Given this list of marker genes Prdx1, Aacs, Calr, Fchsd2, Nsmce3, Idi1, Fabp5, Aldh9a1, Hmgcs1, Pfn1, Gng12, Ly6d, Eef2kmt, Ak2, Ctnnbl1, Hfe, Cfl1, Sdf2l1, Cpped1, Nme1, here is a description of the gene set: Cytokines mediate cell-cell communication in the immune system and represent important therapeutic targets. A myriad of studies have highlighted their central role in immune function, yet we lack a global view of the cellular responses of each immune cell type to each cytokine. To address this gap, the authors created the Immune Dictionary, a compendium of single-cell transcriptomic profiles of more than 17 immune cell types in response to each of 86 cytokines (>1,400 cytokine-cell type combinations) in mouse lymph nodes in vivo. A cytokine-centric view of the dictionary revealed that most cytokines induce highly cell-type-specific responses. For example, the inflammatory cytokine interleukin-1β induces distinct gene programmes in almost every cell type. A cell-type-centric view of the dictionary identified more than 66 cytokine-driven cellular polarization states across immune cell types, including previously uncharacterized states such as an interleukin-18-induced polyfunctional natural killer cell state. from publication Cui A, Huang T, Li S, Ma A, Pérez JL, Sander C, Keskin DB, Wu CJ, Fraenkel E, Hacohen N (PMID 38057668) species: Mus musculus Mouse Gene Set: CUI_PDC_IL4_RESPONSE_UP Genes positively differentially expressed in cell type: pDC (plasmacytoid dendritic cell) upon treatment with cytokine: IL-4 in mouse lymph nodes in vivo.